Given this list of marker genes GART, AHCYL2, MTHFD2, GLRX, MTRR, MTHFD1, SHMT1, MAT1A, ATIC, SHMT2, MTHFR, MTHFS, FOLH1, DNMT1, TCN2, BHMT (betaine--homocysteine S-methyltransferase), AMT, MAT2B, FTCD, AHCY, MTR, DNMT3B, ALDH1L1 (aldehyde dehydrogenase 1 family member L1), DNMT3A, DHFR, TYMS, MTFMT, CHDH, MTHFD1L, here is a description of the gene set: One-carbon metabolism Human Gene Set: WP_ONECARBON_METABOLISM species: Homo sapiens